Given this list of marker genes KRT6A, IKBKG, ZSWIM6, LMNA, WNT5A, KRT14, DVL1, CTSC, PLEC (NCBI Gene Id 5339), LORICRIN, KRT5, GJB2 (gap junction protein beta 2), WDR19, KRT83, KRT16, KLHL24, FZD6, KRT6B, FZD2, DVL3, TP63, EGFR, COL7A1, GJB6, ADAM17, ITGB4, INSR, HPGD, KRT17, here is a description of the gene set: Onychogryphosis is a disorder of nail plate growth that is clinically characterized by an opaque, yellow-brown thickening of the nail plate with associated gross hyperkeratosis, elongation, and increased curvature. Human Gene Set: HP_ONYCHOGRYPHOSIS Onychogryphosis species: Homo sapiens